The following is a description of a gene set: Human Gene Set: MIR4695_5P species: Homo sapiens from publication Chen Y, Wang X (PMID 31504780) Genes predicted to be targets of miRBase v22 microRNA hsa-miR-4695-5p in miRDB v6.0 with MirTarget v4 prediction scores > 80 (high confidence targets)., and this is the list of marker genes: MOSPD3, ANKS4B, STAC, FBXW11, METTL6, HMGB1, OLFML1, RIMS4, JAK3, ATXN7, CLUAP1, ATP6V1A, FANCB, NUMA1, WNT1, SHISA7, RASSF1, NTRK3, RIOK3, PCDHGA12, CEP43, GABRR2, SERBP1, PARP3, UBE2Q1, C7, SHC1, TAF12, SLC25A20, ITGB3, R3HDM1, NDUFA7, TMEM214, PURA, GUCY1A1, SYNGR2, PRKAB2, SYPL2, NECAP1, SFR1, CDH15, CDCA7L, GFPT2, ZSCAN22, ZNF528, PCARE, SLC28A1, FCHSD2, VIPAS39, DMWD, FSTL4, BCAT1, CUX1, GEMIN7, AGO1, ZNF737, TOR2A, GLG1, UBE2D2, DEPTOR (NCBI Gene Id 64798), NCAPG2, CAPN6, IGF1R, RPS6KA5, EEIG1, EFR3B, KIF1C, ZNF704, MYBPC1, BNIP3L, NHEJ1, SERTAD3, WASF2, PAQR4, FOCAD, RNF144B, CEP85, ERI1, SRSF1, RBFA, CENPN, CHMP4C, THEM5, SLC16A1, ZKSCAN3, SPN, CASP8AP2, DPP8